The following is a description of a gene set: Any process that modulates the frequency, rate or extent of eosinophil migration. Mouse Gene Set: GOBP_REGULATION_OF_EOSINOPHIL_MIGRATION species: Mus musculus, and this is the list of marker genes: Ptger4, Ccl24, Il4, Dapk2, Cd300a, Adam8 (NCBI Gene Id 11501)